The following is a description of a gene set: studied in species Mus musculus Mouse Gene Set: GOBP_REGULATION_OF_DENDRITE_MORPHOGENESIS Any process that modulates the frequency, rate or extent of dendrite morphogenesis., and this is the list of marker genes: Nfatc4, Fbxo31, Tnik, Robo1, Anapc2, Neurog3, Actr3, Grip1, Pqbp1 (NCBI Gene Id 631302), Ptprz1, Cux1, Cask, Chrnb2, Sarm1, Marcks, Lzts1, Rap2a, Id1, Epha4, Grin1, Il1rapl1, Tiam1, Fzd4, Cdkl3, Slc30a1, Lrp8, Nedd4, Dhx36, Dlg4, Ilk, Mfn1, Cit, Cdkl5, Caprin2, Pafah1b1, Akap5, Gorasp1, Dpysl5, Reln, Parp6, Pias2, Numb, Mfn2, Gsk3b, Actr2, Hecw1 (HECT, C2 and WW domain containing E3 ubiquitin protein ligase 1), Tlx2, Trpc5, Dbn1, Bhlhb9, Wls, Met, Rab21, Dbnl, Sgk1, Ache, Adgrb3, Itpka, Afdn, Opa1 (NCBI Gene Id 74143), Wnt5a, Myo5b, Hecw2, Tbc1d24, Baiap2, Stau2, Obsl1, Ywhah, Kndc1, Caprin1, Fbxw8, Ss18l1, Ephb2, Eef2k (NCBI Gene Id 97404), Chrna3, Sipa1l1, Pak3, Kalrn, Stk11, Ankrd27, Hdac6 (NCBI Gene Id 20374), Sema4d, Nedd4l, Numbl, Sdc2, Dnm1l, Rapgef2, Cul7 (NCBI Gene Id 66515), Ppp3ca, Xlr3b, Ptprd, Skor2, Cux2, Ptprf, Nsmf, Camk2b, Sh3glb1, Trpc6, Nr2e1